The following is a description of a gene set: Human Gene Set: KRASNOSELSKAYA_ILF3_TARGETS_DN Viral infection triggers a cascade of interferon response genes, but the mechanisms that prime such innate antiviral defenses are poorly understood. Among candidate cellular mediators of the antiviral response are the double-stranded RNA (dsRNA)-binding proteins. Here we show that a C-terminal variant of the ubiquitous dsRNA-binding protein, nuclear factor 90 (NF90ctv), can activate the interferon response genes in the absence of viral infection. NF90ctv-expressing cells were infected with the syncytium-inducing HIV-1 strain NL4-3 and were shown to inhibit viral replication. To gain insight into this mechanism of protection, we analyzed the expression profiles of NF90ctv-positive cells as compared with parental cells transduced with the empty vector. Of the genes represented on the expression arrays, 90 displayed significant (4-fold or more) changes in mRNA levels in NF90-expressing cells. About 50% are known interferon alpha/beta-stimulated genes. The microarray expression data were confirmed by quantitative reverse transcriptase-polymerase chain reaction analysis of six representative interferon-inducible genes. Electrophoretic mobility shift assays showed that the biological response is mediated by the activation of transcription factors in NF90ctv-expressing cells. Functional significance of the activated transcription complex was evaluated by transfection assays with luciferase reporter constructs driven by the interferon-inducible promoter from the 2'-5'-oligoadenylate synthetase (p69) gene. Resistance to HIV-1, caused by the expression of NF90ctv in the cell culture system, appears to be mediated in part by the induction of interferon response genes. This leads to a hypothesis as to the mechanism of action of NF90 in mediating endogenous antiviral responses. Down-regulated in GHOST(3)CXCR4 cells (osteosarcoma) upon ectopic expression of ILF3. from publication Krasnoselskaya-Riz I, Spruill A, Chen YW, Schuster D, Teslovich T, Baker C, Kumar A, Stephan DA (PMID 12036489) species: Homo sapiens, and this is the list of marker genes: CYP19A1, PCK2, UGT8, CDC6, XK, GAL, MAPK7, HMGCS1, TEK, CDH11 (cadherin 11), KIFC1, TROAP, DMD, POLD2, TAF4, AXL, SRSF6, LIG1, NDN, GATM, ARHGAP11A, ROR2, NMT1, CELF2, ASNS, MN1 (NCBI Gene Id 4330), CREBBP, OLFM1, HCFC1, LMNB1, PSPH, SLC1A3, SREBF2, THBS4, ACKR3 (NCBI Gene Id 57007), IRX5, IL6R, COL2A1, NPTX2, RAD52, MYCL, ESPL1 (extra spindle pole bodies like 1, separase), PC, IGFBP5, MSX2 (msh homeobox 2), NT5E